The following is a description of a gene set: Mouse Gene Set: GOBP_ERYTHROCYTE_MATURATION A developmental process, independent of morphogenetic (shape) change, that is required for an erythrocyte to attain its fully functional state. studied in species Mus musculus, and this is the list of marker genes: Ankle1, Gm15915 (NCBI Gene Id 100504069), Epo, Hdac6, Ercc2, Bap1, Epb42, L3mbtl3, Flvcr1, Nemp1, G6pd2, Tal1, Brd1, Trim58, Rac2, Heatr3, Rac1, Zbtb7a, Bloodlinc, Fam210b, G6pdx, Hba-x, Pla2g10, Ptbp3, Klf2, Maea, Klf1 (NCBI Gene Id 17953), Diaph3